The following is a description of a gene set: The transcription factor Foxp3 is usually considered the master regulator for the CD4+CD25+ from publication Hill JA, Feuerer M, Tash K, Haxhinasto S, Perez J, Melamed R, Mathis D, Benoist C (PMID 18024188) studied in species Homo sapiens Genes down-regulated in comparison of ActCD4 versus WTActCD4 (see Fig. 1 in the paper for details). Human Gene Set: GSE7460_WT_VS_FOXP3_HET_ACT_TCONV_DN, and this is the list of marker genes: UCHL3, LYPLAL1, MED30, TAF12, ARID3A, ANXA3, YME1L1, PSMA2, HSDL2, PLEKHA3, PLSCR1, IGHG1, ASB2, RMDN2, BMI1, ZMYM4 (NCBI Gene Id 9202), EIF3J (eukaryotic translation initiation factor 3 subunit J), STXBP4, NHERF4, MATN2, EPHX4, CEP290, SRA1 (steroid receptor RNA activator 1), F2RL2, GHITM, RGP1, KCNG4, PPWD1, PEX2, NEDD4, POMGNT1, CHPT1, SFPQ, RNF19B, EBF4, RANBP6, PSME1, ZDHHC5, F2R, APOOL, NCS1, GZMA, UBE3C, ABI3, IGF2BP3, IRGM, UBE2E3, SMIM3, PPP2R3C, SLCO3A1, LRP10, STRA8, CHST11 (NCBI Gene Id 55807), MLKL, AK7, RYK, CCDC66, GPR65, MTFMT, MRPL35, MCCC1, ZCCHC18, MTIF2, TMEM165, KCTD11, MAP4K1 (NCBI Gene Id 11184), DNAJB6, SERTM1, DLG3, ETFB, UMAD1, ATXN3, GEM, ADAM8, ZMIZ2, GNAZ, TM9SF4, NSMCE2, TAF2, AGFG1, MED27, TMEM88B, CEP162, TDRKH, GCNT7, CDC123, USP47, TMEM62, LAMP2, PIH1D2, CHORDC1, HORMAD2, NPY5R, GLIPR1L1, LPGAT1, NT5M (5',3'-nucleotidase, mitochondrial), SUSD3, GLRX, TMCO1, PTPN13, GLMN, SUCLA2, PTAR1, JMJD4, ALG2, DSG2, PLXDC2, FXR1, UBXN2A, TMED3, CCT4, RPS6KA6, COQ9, NUDT21, NABP1, EIF2AK2, ACP2, QNG1, MAD2L1BP, PSMC5, DCST1, APIP, MPP7, TTC39C, ZBTB37, MAD2L2, DCUN1D5, DROSHA, ARL4A, VMP1, CMTM2, SLC7A6, PCBP2, TRMT11, BMPR1A, AHR, TNFSF10 (TNF superfamily member 10), LGALS3, SEC63, SOAT2, EED, KRAS, SAMD1, TMEM168, GNPTAB, NMT1, KSR1, KYAT3, SEC61G, FRMD4B, PSMD6, ZNF428, CDC73, COPS6, AHCTF1, CDKL2, CXCR3, DUSP5, DEPDC7, STK38L, ADORA2B, ZFTA, EIF4G2, MOSMO, AP4S1, DNAJC18, PEX5L, PTPN11 (NCBI Gene Id 84990), RAB6A, NPR1, CEP78, CST7, TMEM167A, USP42, MLEC, ZSWIM7, IFT43, ZNF131, SUGT1, SLC25A53, CD38, PARL, C1GALT1C1, WSB2, DCLK2, PUS3, ORC4, DRD1 (NCBI Gene Id 1812), MGAT2, RAD1, AOPEP, SDHAF2, ANKRD13C, FNDC3B, MAF, PLIN2, SLC39A4, IL12RB1, PPP2CA